Given this list of marker genes Blzf1, Hsd17b7, Mfap3l, Lrr1, Arhgap6, Hpse, Mbtd1, Gata3, Pcdh20, Zfp72, Ccnj, Sox17, Idi1, Cyp2c38, Frmd7, Tmem38b, Lrrc4c, Zfp955b, Trio, Pum1, Ushbp1, Ep300, Nudt4, Ankle2, Nfx1, Nsd2, Nat3, Aqp1, Ctnnb1, Zfp607b, She, Efemp1, Dlgap1, Rasl12 (NCBI Gene Id 70784), Ly6g6d, Snrnp27, Dnajb14, Erbb4, Gng12, Trp53i11, Palld, Hnrnpa3, here is a description of the gene set: from publication Chen Y, Wang X (PMID 31504780) studied in species Mus musculus Genes predicted to be targets of miRBase v22 microRNA mmu_miR_429_5p in miRDB v6.0 with MirTarget v4 prediction scores > 80 (high confidence targets). Mouse Gene Set: MIR_429_5P